Given this list of marker genes Bloc1s5, Cd63, Ugt1a1, Bloc1s6, Ap1g1 (NCBI Gene Id 52301), Rab32, Krtap21-1, Ap3d1, Shroom3, Ap1m1, Shroom2, Bloc1s3, Rab38, Ankrd27, here is a description of the gene set: Mouse Gene Set: GOBP_PIGMENT_ACCUMULATION The aggregation of coloring matter in a particular location in an organism, tissue or cell, occurring in response to some external stimulus. species: Mus musculus